The following is a description of a gene set: Mouse Gene Set: REACTOME_DNA_STRAND_ELONGATION studied in species Mus musculus DNA strand elongation, and this is the list of marker genes: Rfc5, Prim1, Rfc4, Pold4, Pold2, Gins3, Gins4, Pcna, Dna2, Rfc1, Pold1, Gins1, Rpa1, Prim2, Lig1, Fen1, Pola1, Gins2, Rfc2, Pold3, Pola2, Rfc3, Rpa3, Rpa2